Given this list of marker genes FGF23, PIK3CA, NRG4, NTF3, IRS1, PIK3CD, AKT1, PDGFRA, ERBB2, LCK, INS, PIP4K2C, INSR, PPP2R1A, RAC2, FGF8, EGFR, CD80, ESR2, EPGN, FGFR2, CD19 (NCBI Gene Id 930), FGF18, ESR1, BDNF, FYN, AKT2, KLB, PIK3CB, IL33, PPP2CB, IL1RAP, FGF6, KIT, ICOS, PTPN11, PPP2R5A, FRS2, PPP2R5C, AREG, EGF, NRG3, BTC, TRAT1, EREG, PIK3CG, FGF7, FGF1, NTF4, MAPK3, FGF16, FGF10, TRIB3, FGF17, PIK3AP1, SRC, PDGFRB, ERBB4, PIP5K1B (NCBI Gene Id 8395), PIK3R3, NTRK3, HGF, CD28, PPP2R5E, KL (klotho), FGF9, PIP4K2B, TRAF6, PPP2R5D, RAC1, FGF5, FGF22, PPP2R1B, GRB2, PHLPP1, STRN, NRG2, PTEN, FGF4 (NCBI Gene Id 2249), FGF20, FLT3, PHLPP2, PIP5K1C, IER3, NRG1, FGF3, PIK3R1, IRAK1, MYD88 (MYD88 innate immune signal transduction adaptor), HBEGF, ERBB3, PIP5K1A, FGFR1, MAPK1, FGF2, PIK3R6, PIK3R5, PIK3R2, GAB2, VAV1, FGFR3, PDGFB (NCBI Gene Id 5155), PDGFA, IRS2 (NCBI Gene Id 90066), GAB1, IL1RL1, FGF19, PPP2CA, NTRK2, PIP4K2A, TGFA, CD86, AKT3, FGFR4, PPP2R5B, MET, IRAK4, FLT3LG (NCBI Gene Id 2323, fms related receptor tyrosine kinase 3 ligand), RHOG, THEM4, KITLG, here is a description of the gene set: Reactome Pathway: Negative regulation of the PI3K/AKT network The PI3K/AKT network is negatively regulated by phosphatases that dephosphorylate PIP3, thus hampering AKT activation. studied in species Homo sapiens part of: PIP3 activates AKT signaling